The following is a description of a gene set: part of: SUMO E3 ligases SUMOylate target proteins Reactome Pathway: SUMOylation of RNA binding proteins SUMOylation of RNA-binding proteins alters their interactions with nucleic acids and with proteins. Whereas SUMOylation of HNRNPC decreases its affinity for nucleic acid (ssDNA), SUMOylation of NOP58 is required for binding of snoRNAs. SUMOylation of HNRNPK is required for its coactivation of TP53-dependent transcription. studied in species Homo sapiens, and this is the list of marker genes: NUP88, RAE1, NUP58, NUP133, NUP43, NUP54 (nucleoporin 54), RING1, NUP62, NUP98, TPR, NUP205, RANBP2, NUP93, NUP214, NUP85, NUP107, SEC13, SUMO1, SUMO2, NUP35, SEH1L, NUP160, AAAS, NUP42, NOP58, PHC2, PCGF2, POM121, CBX4, NUP153, RNF2, NUP155, NUP210, BMI1, NUP188, CBX8, PHC1, HNRNPC, UBE2I, POM121C, NUP50 (nucleoporin 50), HNRNPK, NUP37, NDC1, SCMH1, PHC3, CBX2